Given this list of marker genes Slc25a42, Slc25a24, Slc25a41, Slc25a4, Slc25a31, Slc17a9, Slc25a23, Slc25a17, Slc25a5, Slc35b1, here is a description of the gene set: Mouse Gene Set: GOMF_ADP_TRANSMEMBRANE_TRANSPORTER_ACTIVITY Enables the transfer of ADP, adenosine diphosphate, from one side of a membrane to the other. studied in species Mus musculus